Given this list of marker genes STX16, RAB2A, TOM1, STX1A, C9orf72, ANXA2, ATL1, TGFBRAP1, YIPF5, PLEKHM1, PIP4K2A, RUFY4, RAB20, TBC1D4, SLAMF1, SNAP29, VPS4A, VAV3, VPS33B (VPS33B late endosome and lysosome associated), CHMP3, RAB7A, STX7, VAMP3, ZNRF1, RPH3A, VPS39, VAMP7, STX3, SYT9, SYT7, DOC2B, SOX30, CLN3, STX5, PLA2G5, IRAG2, ATL2, RUFY1, YIPF7, CHMP4A, STXBP6, ANKFY1, UVRAG, SYT11, VPS16, STXBP1, BET1, STX1B, RPH3AL, SYT13, VAMP2, RAB14, GRIK5, SNAPIN, RAB34, SPG11, C2CD5, VCPIP1, VPS8, TRARG1, CAV2, ATL3, CORO1A, VPS33A, LRRK2, CPLX4, VPS41, CHMP2A, ERC2, CPLX1, RUBCNL, CHMP4B, SNAP25 (NCBI Gene Id 6616), CPLANE2, SAMD9, SYT4, PIP4K2B, STX2, SPHK1, ZNRF2, ANXA1, SYT2, VTI1A, CHMP1A, STX19, RAB7B, STX8, BNIP1, VAMP1, USO1, TMEM175 (transmembrane protein 175), ARL8B, VAMP4, CPLX2, SEPTIN8, CLTRN, SNAP23, SYT3, ANKRD27, RAB4B, VPS11, DIAPH3, RAB3A, PIKFYVE, NKD2, SYT8, SYT5, STX10, STX12, VIPAS39, ATP13A2, STX17, SNCA (NCBI Gene Id 6622), PRRT2, DOC2A, VPS18, YIPF4, VTI1B, KIAA0319L, CPLX3, TSNARE1, RAB39A, GOSR1, CHMP7, RAB8A, SNAP47, CHMP1B (NCBI Gene Id 57132), STX11, CHMP2B, CHMP4C, CHMP5, STX6, CHMP6, EEA1, SYT1, VAMP8, STX4 (syntaxin 4), GOSR2, here is a description of the gene set: studied in species Homo sapiens The joining of two lipid bilayers to form a single organelle membrane. Human Gene Set: GOBP_ORGANELLE_MEMBRANE_FUSION